Given this list of marker genes Xrcc5, Letm1, Mir29c, Trpv4, Aqp1, Mir99a, Fbp1, Bdkrb2, Mir9-1, Capn3, Mir137, Bax, Anxa7, Mir451a, Mir7b, Xrcc6, Zfp36l1, Agt, Mir9-3, Mir100, Agtr1b (NCBI Gene Id 11608), Th, Ptk2b, Micu1, Nedd4l, Pck1, Slc25a23, Mknk1, Mir204 (NCBI Gene Id 387200), Mir434, Mir29b-2, Efhd1, Mir29b-1, Kmo, Slc12a6, Abcb1a, Mir30b, Mir9-2, Epo, Akr1b1, Hsp90aa1, Agtr1a, Trp53, here is a description of the gene set: studied in species Mus musculus Any process that results in a change in state or activity of a cell or an organism (in terms of movement, secretion, enzyme production, gene expression, etc.) as a result of a stimulus indicating an increase or decrease in the concentration of salt (particularly but not exclusively sodium and chloride ions) in the environment. Mouse Gene Set: GOBP_RESPONSE_TO_SALT_STRESS